The following is a description of a gene set: A posterior embryotoxon is the presence of a prominent and anteriorly displaced line of Schwalbe. Human Gene Set: HP_POSTERIOR_EMBRYOTOXON Posterior embryotoxon studied in species Homo sapiens, and this is the list of marker genes: COMT, HMX1, SEC24C, RFC2 (replication factor C subunit 2), DGCR2, GTF2IRD1, FKBP6, GTF2IRD2, PEX6, PITX2, ELN, ARVCF, GP1BB, SLC38A8, CLIP2, PAX6, TMEM270, NOTCH2, DNAJC30, YAP1, EIF4H, LIMK1, PEX1, HIRA, TBL2, UFD1, NDUFB11, BUD23, JAG1, HS2ST1, STX1A, PEX19, METTL27, FOXC1, KDM5A, PEX14 (peroxisomal biogenesis factor 14), TBX1 (T-box transcription factor 1), HCCS, PEX5, JMJD1C, RREB1, PEX16, DGCR6 (NCBI Gene Id 8214), DGCR8, GTF2I, PEX3, ESS2, PEX12, BAZ1B, PIK3R1, NCF1, VPS37D, PEX2 (NCBI Gene Id 5828), PEX11B, PEX10, PEX26, PEX13, COX7B